The following is a description of a gene set: Human Gene Set: GOMF_NUCLEAR_THYROID_HORMONE_RECEPTOR_BINDING studied in species Homo sapiens Binding to a nuclear thyroid hormone receptor., and this is the list of marker genes: MED16, ARID5A, MED12, MED24, NCOR1, GTF2B, TRIP6, NSD1, TAF11, MED1, THRAP3, PRMT2, MED4, MED17, TAF7, JMJD1C, MED13, BRD8, HMGN3, OASL, NR0B2, ZNHIT3, NCOA6, TRIP12, TACC1, GTF2H1, NCOA3, MED30